The following is a description of a gene set: studied in species Homo sapiens An anomaly of the fifth metatarsal bone. Abnormality of the fifth metatarsal bone Human Gene Set: HP_ABNORMALITY_OF_THE_FIFTH_METATARSAL_BONE, and this is the list of marker genes: GNAS, IQCE, TCF4, CDC42BPB, RIPK4, HOXD13, FLNA, ERI1, HEPHL1